Given this list of marker genes ARHGAP29, IQGAP1, PLAT (plasminogen activator, tissue type), NKAPD1, DHX32, CSNK1E, ITGA6, LGMN, SLC35D2, SPATS2L, BCL3, TMSB4X, VCPIP1, RPS6KC1, TNFRSF1B, BTG1, SOX4, NFE2L2, KCTD3, DUSP4, SKIL, PIP4K2B, LIMA1 (NCBI Gene Id 51474), DDIT4, ERGIC1, PDLIM7, FCHO2, NAB1, NRP1, EPG5, SGK1, HMGXB4 (NCBI Gene Id 96789), C9orf72, PLEKHA3, GRB7, BCL2L14, CRCT1, GNG13, FOXQ1, FGD6, GGA3, TBC1D1, EXOC7, IFNGR1, SLC29A1, SMAD7, MOK, EMD, TGFBR1, PALMD, SLC6A8, TMX2, GTSE1, VIM, HMBS, CPD, AFP, MAP3K20, NCS1, MAL2, FOSL2 (NCBI Gene Id 79579), PICALM, PIGH, SPPL2A, NGF, CLDN4, RBM47, BHLHE40, SOX9, UAP1L1, RASSF8, PDGFA, IKBKE, ASNS, LMO7, ALS2, NBEAL1, MAML2, UNC5B, TGIF1, SLC20A1, NET1, UBR2, PDCD10, IER3, LPGAT1, AMD1, CCN2, PMEPA1, IMPACT, CXCL1, SPRR3, CLIC4 (chloride intracellular channel 4), SMURF2, TEX10, GJA5, CXCL10, TBCEL, SLC40A1, SLC48A1, SERPINE1, DDR1, PRUNE1, SQLE, HSPA4, ZCCHC10, TFPI2, IDI1, CHMP4C, here is a description of the gene set: 'Late-TGFB1 signature': genes overexpressed in primary hepatocytes at a late phase of TGFB1 treatment; is associated with a more invasive phenotype. Hepatocellular carcinoma (HCC) is one of the most common cancers in the world. The clinical heterogeneity of HCC, and the lack of good diagnostic markers and treatment strategies, has rendered the disease a major challenge. Patients with HCC have a highly variable clinical course, indicating that HCC comprises several biologically distinctive subgroups reflecting a molecular heterogeneity of the tumors. Transforming growth factor beta (TGF-beta) is known to exhibit tumor stage dependent suppressive (that is, growth inhibition) and oncogenic (that is, invasiveness) properties. Here, we asked if a TGF-beta specific gene expression signature could refine the classification and prognostic predictions for HCC patients. Applying a comparative functional genomics approach we demonstrated that a temporal TGF-beta gene expression signature established in mouse primary hepatocytes successfully discriminated distinct subgroups of HCC. The TGF-beta positive cluster included two novel homogeneous groups of HCC associated with early and late TGF-beta signatures. Kaplan-Meier plots and log-rank statistics indicated that the patients with a late TGF-beta signature showed significantly (P < 0.005) shortened mean survival time (16.2 +/- 5.3 months) compared to the patients with an early (60.7 +/- 16.1 months) TGF-beta signature. Also, tumors expressing late TGF-beta-responsive genes displayed invasive phenotype and increased tumor recurrence. We also showed that the late TGF-beta signature accurately predicted liver metastasis and discriminated HCC cell lines by degree of invasiveness. Finally, we established that the TGF-beta gene expression signature possessed a predictive value for tumors other than HCC. CONCLUSION: These data demonstrate the clinical significance of the genes embedded in TGF-beta expression signature for the molecular classification of HCC. Human Gene Set: COULOUARN_TEMPORAL_TGFB1_SIGNATURE_UP from publication Coulouarn C, Factor VM, Thorgeirsson SS (PMID 18506891) studied in species Homo sapiens